The following is a description of a gene set: Human Gene Set: BASAKI_YBX1_TARGETS_UP studied in species Homo sapiens from publication Basaki Y, Hosoi F, Oda Y, Fotovati A, Maruyama Y, Oie S, Ono M, Izumi H, Kohno K, Sakai K, Shimoyama T, Nishio K, Kuwano M (PMID 17072343) Genes up-regulated in SKOC-3 cells (ovarian cancer) after YB-1 (YBX1) knockdown by RNAi. Y-box-binding protein 1 (YB-1), which is a member of the DNA-binding protein family containing a cold-shock domain, has pleiotropic functions in response to various environmental stimuli. As we previously showed that YB-1 is a global marker of multidrug resistance in ovarian cancer and other tumor types. To identify YB-1-regulated genes in ovarian cancers, we investigated the expression profile of YB-1 small-interfering RNA (siRNA)-transfected ovarian cancer cells using a high-density oligonucleotide array. YB-1 knockdown by siRNA upregulated genes, including MDR1, thymidylate synthetase, S100 calcium binding protein and cyclin B, and downregulated genes, including CXCR4, N-myc downstream regulated gene 1, E-cadherin and phospholipase C. Exogenous serum addition stimulated YB-1 translocation from the cytoplasm to the nucleus, and treatment with Akt inhibitors as well as Akt siRNA and integrin-linked kinase (ILK) siRNA specifically blocked YB-1 nuclear localization. Inhibition of Akt activation downregulated CXCR4 and upregulated MDR1 (ABCB1) gene expression. Administration of Akt inhibitor resulted in decrease in nuclear YB-1-positive cancer cells in a xenograft animal model. Akt activation thus regulates the nuclear translocation of YB-1, affecting the expression of drug-resistance genes and other genes associated with the malignant characteristics in ovarian cancer cells. Therefore, the Akt pathway could be a novel target of disrupting the nuclear translocation of YB-1 that has important implications for further development of therapeutic strategy against ovarian cancers., and this is the list of marker genes: COMMD4, TK1, KIF2C, GALNT2, MED8, FOXE1, LMNB2, CAD, SAR1B, PRPF3, SMAD7, DDB2, NUDT5 (NCBI Gene Id 11164), DTYMK, MIDEAS-AS1, ADRB2, KLC1, DKK1, RND3, SCO1, AREG, DHX9, MIS18A, RHOD, CEP55, FBN1, RRAD (NCBI Gene Id 6236), CDK1, CDC42EP3, SKA2, FGFBP1, PSMD2, KIF23, PSMB6 (proteasome 20S subunit beta 6), FOLR3, SH3BP4, NUP93, NPFFR2, DEPDC1B, UHRF1, ANLN, BDNF, TSC22D2, COX20, BORA (BORA aurora kinase A activator), RFLNB, PLK2, LARP6, SMC2, DDX39A, ZWINT, CCM2, MCM7, DNAJC9 (NCBI Gene Id 23234), CHEK1 (NCBI Gene Id 1111), LINC02901, THBS1, WWC1 (NCBI Gene Id 23286), PBK, CREBZF, SLC52A2, AJUBA, GLRX2, AXL, AFAP1L1, EHD2, DR1, MELK, SAE1, CCNA2, ZNF599 (NCBI Gene Id 148103), NSD2, EMP2, GSTP1 (NCBI Gene Id 2950), LINC02274, EPHA2, TCP11L1, TSEN15, PLAC8, NMU, GINS2, PGAM5, ZNF185, S100A2, CENPA, MT1G, CENPW, FLNA, COTL1, MISP, S100A3, DKK3, NTN4, DHFR, DTL, ZNG1A (NCBI Gene Id 57397), MAP1B, MCM4, TUBA4A, TUBA1A, FAM83D, TYMS, RBM19, BIRC5, MYO19, MT2A, TPRKB, TPM4, DAZAP1, MT1F, MTHFD1, L1CAM, FLNB, MIR221, OSMR, CDK2, CTPS1, SHCBP1, CENPN, CRIM1-DT, CENPU, CCNB2, C11orf24, RBPMS, WNT10A, SPDL1 (NCBI Gene Id 54908), MT1X, PROSER2, MCM10 (minichromosome maintenance 10 replication initiation factor), CDA, MDC1, SIVA1, TNFRSF12A, CSTF3, CTH, MCM5, ASF1B, DEPDC1, HINT1, CDCA3, SLC1A5, NFKBIA, ANXA8, CYTH3, CHORDC1, FEN1, RNMT, RANGAP1, ASPM, RAD51, SLC39A4, MTCL1, PRKDC, CHAF1A, CDKN3, AHSA1, PRSS23, CAVIN1, TUBB4B, DPYSL3, SLC38A10, TUBB6, RFC3, CCN1, AURKA, MCM3, SLC3A2, UCA1, ESPL1, ALYREF, SMPD4, PLCB4, NCAPD2, GINS1, CENPI, GTSE1, LRR1, SNRPA1, SPC24, CAMTA1, E2F7, PLK1, OIP5, KRT80, CENPO, ZNF71, EMSY-DT, WDR1, ILF2, MAD2L1, GLS, WDR77, H2AZ2, FRMD6, PRC1, TNFRSF21, DDX11, DLC1, RRS1, TXNIP, CDK2AP2, DHRS11, MCM2, PHLDB2, POLA2, ATL3, PSMC3IP, DIAPH3, BUB1, DCUN1D5, UNG, PTTG1, TUBB2A, PDLIM7, H2AX, CEP15, WDR4, RFC5, NEK2, CCN2, NDUFS6, FGF2, PMEPA1, MARS1, NUF2, SAC3D1, SFN, MYBL1, CCND3, GART, S100A11P1, TPX2, RUSC1, ACTR1A, NUP50, ARPC5L (NCBI Gene Id 81873), HJURP, CREM, KNSTRN, BUB1B, WDHD1, HMGB2, ANXA3, NID2 (NCBI Gene Id 95183), FANCI, POLR2L, KIF22, RNF26, KIF20A (kinesin family member 20A), TUFT1, RHEBP1, ZWILCH, KRT10, PINK1, TIMP2 (NCBI Gene Id 7077), TOMM5, SMG5, CACYBP, IMMP1L, RFC2, GLI2, KPNA2, AURKB, RRAS, UBE2C, LINC01224, NDC80, IFRD2, SLC7A5, EHD4, ORC6, CDC20, PDCD2, SNX5, ZNF367, PHF19, CENPM, CDCA8, SNAI2, HTATIP2, JPT1, MKI67, IRAK1, KIF4A, YWHAH, HAT1, CAV1, CDC6, LAMC2 (NCBI Gene Id 3918), PRELID1, CCNB1, TRIP13, CNOT9, PEX13